Given this list of marker genes Agt, Csf1r, Grn, Nr1d1, Zeb2, Ifng (NCBI Gene Id 15978), Cntf, Psen1, Adora2a, App, Ifngr1, Ldlr, Egfr, Il1b, C1qa, Smo, Naglu, C5ar1, Trem2, Lrp1, Ager, here is a description of the gene set: studied in species Mus musculus Mouse Gene Set: GOBP_ASTROCYTE_ACTIVATION A change in morphology and behavior of an astrocyte resulting from exposure to a cytokine, chemokine, cellular ligand, or soluble factor.